Given this list of marker genes Itsn1, Itln1, Cacnb2, Prkci, Kif5b, Snap25, Thy1, Pcm1, C1qtnf2, Arhgef11, Spp1, Atp1b2, Isl1, Prl2c2, Mapk14 (mitogen-activated protein kinase 14), Cox17, Akap7, Fpr-rs4, Cntf, Sytl4, Clu, Pink1, Gip, Lipg, Rab9, Prap1, Pla2g6, Kcnc2, Bcap31, Kcnh2, Ano1, Cck, Erbb4, Fgf12, Nod2, Or51e2, Lypd11, Negr1, Ces1f, Wnt5a, Ighg2b, Rims1, Glud1, Cnst, Lrrc52, Pparg, Scamp5, Scp2, Ppt1, Gpc3, Cdh1, Rimbp2, Mertk, Slc7a5, Pla2g10, Slc38a1, Trpm5, Anxa7 (NCBI Gene Id 11750), Mchr1, Abcb1b, Apln, Myh9, Prl3d3, Eif3e, Amigo1, Magi2, Ran, Stac3, Rdx, Apbb3, Tcaf1, Acsl6, Rph3al, Cartpt, Sfn, F2rl1, Stim2, Dlg1, Reln, Plcd1, Prl2a1, Sirt6, Siva1, Fmr1, Insr, Eepd1, Prl8a8, Serp1, Pck2, Mbl2, Hip1r, Tmem132a, C2cd5, Galr1, Rab7, Abca5, Aacs, Ces1c, Hdac3 (histone deacetylase 3), Arrb1, Efcab7, Il2rg, Psen1, Lpar3, Lep, Trpm2, Stx1b, Grin1, Rap1gap, Abr, Nat8l, Pdcd5, Cacna1i, Aoc3, Dnm2, Il15ra, Brca1, Coa8 (cytochrome c oxidase assembly factor 8), Ehd2, Cdc42, Pdcd6ip, Grm6, Trpc1, Irs2, Tmem30a, Adora3, Fgf13, Lrrc8a, C1qtnf12, Acsl4, Tgfb1, Rph3a, Syt1, Actn2, Trpc4, Rack1, Tescl, Irs1, Slc2a2, Ehd1 (EH-domain containing 1), Lrp2, Flna, Ocln, Add1, Prl7a2, Il6, Sybu, Itgb2l, Myrip, Mecp2, Oxtr, Abcc8, Dync1h1, Rab31, Kcnn2, Dnm1, Tac1, Ang6, Cyp4a10, Sirpb1a, Pcp4, Myo5b, Fxyd3, Htr2c (NCBI Gene Id 15560), Hip1, Msn, Hnrnpm, Lrrc26, Ankrd1, Prkaca, Malrd1, Pcsk9, Npsr1, Hsp90ab1, Pltp, P2ry2, Pex5l, Akap9, Ffar1, Stam, Gal, Car2, Casq1, Wipf1 (NCBI Gene Id 98855), Il1a, Ces1a, Vamp8, Arf6, Exoc2 (NCBI Gene Id 66482), Slc18a3, Rufy3 (NCBI Gene Id 72186), Fxyd1, Fgg, Syt3, Rufy4, Pkd2, Pla2g4e, Stac, Gprc6a, Hyal2, Cep290, Prkn, Gnaq, Tsg101, Osbpl8, Ier3ip1, Pycard (NCBI Gene Id 66824), Fcgr3, Ppp3cc, Grem1, Runx1, Gata2, Prl8a9, Colec10, Avpr1a (NCBI Gene Id 54140), Cd4, Cacna1c, Tmed10, Frmd4a, Mlc1, Pdcd5-ps, Tm7sf3, Abat, Retn, Ighm, Jak3, Pclo, Lif, Cx3cl1, Grik1, Nutf2-ps1, Calr, Atp2c2, Bicd1, Sod1, Nherf1, Il15 (interleukin 15), Ccr1, Crebl2, Stk39 (NCBI Gene Id 99416), Cxcr3, Zc3h12a, Nipsnap2, Rab3b, Nr1h2, Nr1h4, Pla2g5, Cdk5, Ces1h, Sphk2, Ppid, Sele, Cltrn, Vegfc, Lrat, Drd2, Dpysl2, Pcsk1, Atf4 (activating transcription factor 4), Psmd9, Ptpn5, Ice1, P2ry1, Camk1, Mex3b, Abcg1, Ccl12, Smpd3 (sphingomyelin phosphodiesterase 3, neutral), Scn4b, Pdgfrb, Tac4, Ppp3cb, Hspa8, Park7, Klf15, Ppia, Rgcc, Nckap1l, Rbm22, Pla2g3, Nlgn3, Lilra5, Ap2b1, Itga2, Unc13d, Sumo1, App, Slc26a6 (NCBI Gene Id 171429), Ect2, Cracr2a, Prkcd, Slc12a2 (solute carrier family 12, member 2), Ghrhr, Tgfb2, Stim1, Slc18a1, Galr2, Gja1, G6pd2, Mdm2, Gsk3a, Trpv3, Wasl, Sct, Prl8a6, Gpd1l, Il1b, Arrb2, Syt13, Ccl2, Mfn2, Gna11, Atp8a2, H1f1, Cpsf6, Fhl1, Pfkm, Cd38, Cxcr4, Cd151, Edn1, Lman2, Dcx, Nppa, Rab15, Ikbkb, Il13, Cxcl10, Pirt, Aqp2, Myom1, Rhbdd1, Ins1, Lbp, Chp1, Erfe, Prrt2, Syt4, Cep131, Pgrmc1, Syt10, Calm3, Dmd, Rab5a, Prkcq, Gli3, Sri, Cntn1, Stx1a, Rab2b, Nlgn2, Abca7, Tek, Lrrk2, Prl7c1, Cadps, Prelid1, Gnas, Slc38a3, Fpr-rs6, Snap91, Cyp2j5, Egfr, Akt3, Mpc2, Rbp4, Chmp2a, Septin5, Sdc1, Aplnr, Cdh2, Dpp6, Cav1, Oxt, Abcb1a, Prl, Itgam, Fcgr1, F2r, Riok2, Rnf207, Adcy8, Cd47, Erbb3, Vps28, Rgs7, Kcnj2 (potassium inwardly-rectifying channel, subfamily J, member 2), Sec16b, Pick1, Mbl1, Akap6, Dnm3, Cdh3, Atp5if1 (NCBI Gene Id 11983), Jak2, Ager, Fgf15, Rab27a (NCBI Gene Id 75673), P2rx5, Stc1, Gcg, Emd, Camk2n1, Picalm, Cyp19a1, Rapgef3, Fxyd2, Ppard, Myo18a, Ntsr1, Eef2k, Prl6a1, Adora1, Vmp1, Stxbp5, Hap1, Abcb11, Lrp1, Ccl21a, Slc11a1, Zpr1, Cxcl12 (C-X-C motif chemokine ligand 12), Gimap3, Apoe, Cyp4a31, Lamp1, Golph3, Calm2, Atp13a2, Cacnb3, Ppp3ca, Plk2, Cyp4a32, Camk2a, Ppp3r2, Edn3, Pcnt, Cldn16, Sorbs1, Cd19, Ahcyl1, Ptprc, Prl4a1 (prolactin family 4, subfamily a, member 1), Cacna1g, Baiap3, Appl1, Atp7a, Mib1, Prl3c1, Ms4a1, Slc9a1, Nmb, Wnk1, Hbp1, Scn5a, Pdgfb, Tmem30b, Unc13a, Ptpn23, Prl8a1, Selenot, Lrrc38, Hrh3, Crh, Lhcgr, Hyal3, Tub, Stap1, Gipr, Npy2r, Rab29, Ywhae (tyrosine 3-monooxygenase/tryptophan 5-monooxygenase activation protein, epsilon polypeptide), Tbc1d20, Zdhhc8, Akt1, Vamp2, Pik3r2, Abca8b, Oaz2, Tnf, Tacr1, C2cd2l, Ccl5, Tnfrsf11a, Prl3b1, Sphk1, Sftpd, Bad, C1qtnf3, Stimate, Prr5l, Dmap1, Fxyd6 (FXYD domain-containing ion transport regulator 6), Arap1, Stxbp1, Tmed10-ps, Scn3b, Syt11, Heph, Bcr, Mif, Gps2, Htr6, Abcg4, Sstr4, Mlxipl, Hcar2, Dynll1, Asph, Vps4a, Repin1, Ncs1, Hnf1a, Triap1, Syt2, Cadps2, Mef2a, Adora2b, Sdc4, Drd1, Kif3a, Gimap5, C3, Arhgef5, Nf2, Dab2, Kcnmb1, Mylk, Trpa1 (NCBI Gene Id 277328), Gata1, Sfrp4, Cxcl1, Hspa2, Htt, Ces1g, Lgals3, Ap2a1, Plp1, Ucn, Ep300, Il2rb, Gpld1, Grk2, Map1lc3b (NCBI Gene Id 67443), Foxl2, Crhr1, Nkx3-1, Nfe2l2, Sh3gl1, Vtn (NCBI Gene Id 22370), Kctd7, Avpr1b, Synj2bp, Ecrg4, Clasp2, Sgip1, Ptpn11, F2, Bax, Slc30a8, Rap1a (RAS-related protein 1a), S100a8, Myh10 (NCBI Gene Id 77579), Jph2, Grin2b, Tulp1, Adrb2, Cbll1 (NCBI Gene Id 104836), Tardbp (NCBI Gene Id 97174), Ctss, Pla2g4a, Ahsg, Bag3, Ankfy1, Pou4f2, Tlr4, Sec24a, Prl3a1, Ucn3, Cd160, Adora2a, Nfkb1, Ckap5, Ahi1, Syk, Washc1, Scn2b, Atp8a1, Ptx3, Glp1r, Atp2c1, Ffar4, Slc1a2, Trpc3, Rab3gap1, Angpt1, Ang, Nos1, Zfand1, Tenm1, Ace2, Rtn4, Plaa, Bglap2, Commd1, Abl1, Ncbp2, Capn10, Acsl5, Prkar1a, Lepr, Ap2m1, Znrf1, Trpm4, Map2, Slc4a8, Ppp3r1, Pdpk1, Adipor2, Pdcd10, Atg5, Nr3c1, Rapgef4, Wnt3a, Fgr, Atp2a1 (NCBI Gene Id 11937), Tbc1d5, Atad1, Smad4, Tomt, Mapk9, Orai1, Oxct1, Cyba, Oaz3, Wls, Cd2ap, Ccr1l1, Alox12b, Pik3r1, Gstm7, Amph, Shh, Abca3, Cyp27b1, Prl8a2, Homer1, Strit1, Prl7a1, Met, Oga, Braf, Erc1, Abca13, Gper1, Atpsckmt, Trpv2, Akt2, Tnfrsf1a, Kcnn4, Cbl, Prl2c5, Cfp, Cln3, Hamp2, Ldc1, Syt5, Prl7d1, Stxbp2, Numa1, Trh, Cd177, Fpr-rs7, Slc34a1, Serpine1, Jup, Bmp6, Gpr27, Dnm1l, Ank3, Eipr1, Fxyd7, Ins2, Cckar, Cdk5r2, Cftr (NCBI Gene Id 547216), Prl3d2, Btk, Zdhhc2, Prl2c1, Src, C2, Gabbr1, Apbb1, Lypd10, Prl2b1, Ccr7, Arhgef7, Adrb1, P2rx7, G6pdx, Nnat, Azin1, Stx4a, Trim46, Gpr39, Sdcbp, Oaz1, Syt7, Nppc, Itgb1, Aimp1, Chrnb2, Bak1, P2ry12, Nell2, Bmp2, Vdr, Tmf1, Wnk2, Atp1b1, Hamp, Tfr2 (transferrin receptor 2), Rab27b, Atp2b1, Glul, Fasl, Atp1b3, Zfp13, S100a9, Khdrbs1, Cxcl9, Doc2g, Rab21, Kiss1r, Sirt3, Abca8a, Agtr1a, Tert, Nucb2, Tcf7l2 (transcription factor 7 like 2, T cell specific, HMG box), Anxa1, Nrde2, Ptafr, Ighg1, Adcyap1r1, Abcb4, Kcnc1, Creb1, Ank2, Itpr1, Clasp1, Vps35, Caly (NCBI Gene Id 76271), Cask, Gsto1, Rasl10b, Syt9, Nherf2, Dctn1, Slc30a3, Cd300lf, Mmp13, Tor1a, Anp32b, Gpr68, Il4ra, Xrcc4, Pth, Cav3, Dgkd, Nadk, Doc2b, Blk, Bmp4, Prl7b1, Ptprj, Plcg2, Sftpa1, Hsp90aa1, Tunar, Appl2, Cpb2, Hcls1, Tacr2, Kmo, Trem2, Mff, Ptpn22, Acsl1, Atp2b2, Vps11, Trdn, Arf1, Capn3, Slc17a8, Rims2, Ces1b, Cckbr, Avp, Prl2c3, Smpd1, Akap5, Pros1, Rhoq, Fpr-rs3, P2ry6, Snf8, Ptgs2, Calm1, Ndufa4, Aqp1, Snx4, Azin2, B3gat3, Adam9, Snca, Edn2, Cemip, Nkx2-5, Chchd10, Opn3, Itgb2, Apoa2, Rasa1, Xpo4, Bglap, Dtnbp1, Alms1, Dbi, Borcs5, Arl6ip1, A1cf, Fcer1a, Gab2, Gpr158, Nlgn1, Nkx6-1, Acsl3, Nfkbia, Cacna1h, Fgfr4, Acvr2a, Clec7a, Prkce, Cd36, Dspp, Grp, Rab8b, Agt, Cacna1b, Gh, Inpp5k, Gck, Stk11, Hfe, Gas6, Casr, Slc51b, Ccl19, Actn4, Rapgef1, Ak1, Prss8, Nedd4, Trf, P2rx1, Osbp, Mllt6, F2rl3, Crhr2, Prl3d1 (NCBI Gene Id 18775), Camk4 (calcium/calmodulin-dependent protein kinase IV), Cd81 (NCBI Gene Id 12520), Slc6a1, Bok, Pla2r1, Colec11, Cdk1, Nedd4l (neural precursor cell expressed, developmentally down-regulated gene 4-like), Ano6, Fto, S100a10, Sox4, Gsk3b, Dhx9, Hif1a, Pard6a, Ffar2, Npr3, Ppm1a, Ptger4, Stac2, Nr0b2, Sirt1, Ap1g1, Flot1, Drd4, Unc13b (unc-13 homolog B), Myb, Gjc2, Rfx6, Edem1, Cd14, Smo, Rab3a, Ttn, Ptbp1, Fga, Hnrnpk, Apoa1, Kcnip2, Nsf, Fxyd4, Cnksr3, Mtmr2, Zp3, Ctdspl2, Cd209b, Ednra, Vegfa, Ang5, Lcn2, Igf1, Hcrt, Pon1, Erc2, Adipoq, Exph5, Prkcb, F2rl2, Fgb, Tspo, Cacna1d, Ccl3, Camk1d, Cebpb, Zfp384, Fcnb, Bsg, Fez1 (NCBI Gene Id 235180), Rac1, Zic1, Oprk1, Atg7, Ehd3 (EH-domain containing 3), Il4, Clec4b1, Tmem97, Wnk4 (WNK lysine deficient protein kinase 4), Chrm1, Tgfb3, Ms4a2, Fgfr1, Prl5a1, Tm9sf4, Inhbb, Sirpa, Sox11, Sgk1, Ang2, Sorl1, Pgap1, Nr1h3, Dll1, Abca1, Chp2, Fgf21, Syngr3, Clip3, B2m, Axl, Anxa2, Xbp1, Bcl2l1, Cxcl11, Fgf14, Sytl2, Wnk3, Plk3, Dock2, Kcnb1, Prpf4b, Syt8, Ang4, Tlr2, Pfkfb2, Fcer1g, Ghrh, Bdkrb1, Cd63, Mavs, Vsnl1, Tnfsf11, Egf, Hcfc1, Rnasel, Xcl1, Ghrl, Dennd5b, Kiss1, Prkca, Edem2, Adcyap1, Map2k6, Ildr1, Ntf3, Ipo5, Clcf1, Apela, Chrm3 (NCBI Gene Id 12671), Ces1e, Ptch1, Micu3, Kcnq1, Rab3d, Kcne5, Fpr2, Wfs1, Trpc6, Plcb1, Mapk1, Slc36a2, Synj1, Hgs, Fabp3, Slc6a4, Kcne1, Ubr5, Fxyd5, Uaca, Slc35d3, Tpr, Bin1, P2rx4, Nr4a3, Ifng, Lyar, Abca12, Ncoa6, Creb3, Ripor1, Vps4b (NCBI Gene Id 319619), Ptk2, Stx18, Znrf2, Trim28, Fcgr2b, Tesc, Lpcat3, Rab34, Lrrc55, Ldlrap1, Nutf2, Prkcz (NCBI Gene Id 97193), Ergic3, Doc2a, Smim43, Mcu, Prkd1 (protein kinase D1), Kif20b, Pdx1, Ptges, Nmu, Scn1b, Ezr, Pld2, Pard3, C1qtnf1, Plcg1, Ces1d, Spag5, Golph3l, here is a description of the gene set: Mouse Gene Set: GOBP_POSITIVE_REGULATION_OF_TRANSPORT Any process that activates or increases the frequency, rate or extent of the directed movement of substances (such as macromolecules, small molecules, ions) into, out of or within a cell, or between cells, by means of some agent such as a transporter or pore. species: Mus musculus